The following is a description of a gene set: Human Gene Set: GOBP_NEGATIVE_REGULATION_OF_T_CELL_DIFFERENTIATION_IN_THYMUS Any process that stops, prevents, or reduces the frequency, rate or extent of T cell differentiation in the thymus. studied in species Homo sapiens, and this is the list of marker genes: BMP4, ERBB2, IHH, PTPN2, FOXJ1, ZC3H8, CLEC4G, SHH, RAG2, CDKN2A, TMEM131L